The following is a description of a gene set: Genes down-regulated in comparison of dendritic cells (DC) stimulated with LPS (TLR4 agonist) at 8 h versus DC cells stimulated with Pam3Csk4 (TLR1/2 agonist) at 8 h. studied in species Homo sapiens Human Gene Set: GSE17721_LPS_VS_PAM3CSK4_8H_BMDC_DN from publication Amit I, Garber M, Chevrier N, Leite AP, Donner Y, Eisenhaure T, Guttman M, Grenier JK, Li W, Zuk O, Schubert LA, Birditt B, Shay T, Goren A, Zhang X, Smith Z, Deering R, McDonald RC, Cabili M, Bernstein BE, Rinn JL, Meissner A, Root DE, Hacohen N, Regev A (PMID 19729616) mouse primary BMDCs were stimulated with tlr ligands and gene expression changes were profiled on Affymetrix arrays, and this is the list of marker genes: KLB, GGH, NPRL3, ATRAID, SLC39A9, KPNA6, ANXA9, AKR1B15, HVCN1, MRPL52, OXCT1, MT2A, BMS1, MORF4L1, CXCL6, SAA1, RNF185 (NCBI Gene Id 91445), PTPN1, KCTD1, BTF3L4, WBP2, EIF4E, HLX, NUDCD1, ATP6V0B, RAI1, FIGN, AHSA1, HM13, SKP1, ATL2, MSANTD3, ATP5MC1, SURF2, E2F6, MAPK11, NSUN2, EMILIN1, CTDSP1 (CTD small phosphatase 1), ST7, TMEM176B, RDH10, MRPL3, RLIG1, DNAJC18, EIF2AK4, DDX18, RPP14, RASA1, NOCT, KRI1, GRK6, C6orf136 (chromosome 6 open reading frame 136), CXCL3, ANAPC13, CAT, TEX101, ETFRF1, CDADC1, MRPS12, BLVRA, CLCC1, ACOT7, NFS1, RPL14, LCE1A, GUSB, KCNK13, RASSF8, MICOS13, ZC3H12C, CORO1C, IMPA1, NPM1 (nucleophosmin 1), FPR1, MIA2, HTATIP2, STARD7, HERC1, DHRS7B, YPEL3, PWP1, C5orf34, FKBP15, NUDT2, UBL3, LAPTM5, LIPA, ZFP36L2, PRKCSH, RPS10, CD1D, ADORA2B, SDF2, CCDC47, YIPF4, MRPL11, GALK2, POLR2E, ATP2A2, PAQR7, EIF5, DOCK5, CCT3, ADAM23, B3GALNT2, NBEAL2, MRPS18A, PCTP, DESI2, ACOT8, SUN1, KCNAB2, NXT1, HSD17B12, RNASEH2C (NCBI Gene Id 84153), HGSNAT, RCC1L, FUBP1, TCEA2, WBP1, MYO7A, VPS35L, ZNF329, COMMD6, MRPS2, TBCE, FTSJ1, RPL5, TNRC6C, RPL37A, SIGLEC7, UBA2, PC, MRPL41, PTPMT1, SMC6, AQR, MYDGF, KRR1, IPO9, NDUFA7, MINDY1, RAB31, BET1, ETFDH, PDE8A, SMC3, CAPN7, ITGA6, CLTB, FUCA2, DARS1, CYB5A, GABRA2, RENBP, ARHGAP9, NDFIP1, KLF7, EIF3L (eukaryotic translation initiation factor 3 subunit L), SEC62, HMOX1, PDIA6, ZW10, RWDD3, MME, CALR, YBX1, ACVRL1, GFER, PAFAH2, TPRG1L, MIA3, DNAJC4, EEF1D, TRAPPC2, PPIB, UQCRC1, NISCH, MYADM, UBE2J1 (ubiquitin conjugating enzyme E2 J1), GLTP, OTULINL, GCOM1, NOP2 (NOP2 nucleolar protein), MED14, RAB33A, POLD4, RACK1, PPARG, DPH5, TRMT2A, EIF3H, ATP5F1C, SNAPIN, SCGB3A2, GPAM, ANKRD28, MYO9B